Given this list of marker genes HSPA8, CLTC, GAK, SYNJ1, DNAJC6, here is a description of the gene set: Human Gene Set: GOBP_CLATHRIN_COAT_DISASSEMBLY The disaggregation of a clathrin coat into its constituent components; results in stripping or removing the clathrin coat from clathrin-coated vesicles (CCV) before fusing with their targets. CVVs transport cargo from plasma membrane and trans-Golgi to the endosomal system. studied in species Homo sapiens